The following is a description of a gene set: Subpathway representing multi-drug resistance (MDR) gene regulated by NFE2L2 (NRF2). These MDR-related genes are known to play a role in Drug resistance. For example, ABCF2 have a role in Cisplatin resistance in ovarian cancer. Similarly ABCC1 (MRP1), ABCC3 and ABCG2 also have a role in multiple drug resistance (Cole et al,2014; Zeng et al,1999; Mo et al, 2012). Reactome Pathway: NFE2L2 regulating MDR associated enzymes part of: Nuclear events mediated by NFE2L2 studied in species Homo sapiens, and this is the list of marker genes: EP300, ABCF2, ABCC1, NFE2L2, MAFK, CREBBP, ABCG2, ABCC3